The following is a description of a gene set: The glycosylation of protein via the O3 atom of peptidyl-serine, forming O3-glycosyl-L-serine; the most common forms are N-acetylgalactosaminyl, mannosyl, galactosyl, and xylosyl serine. Mouse Gene Set: GOBP_PROTEIN_O_LINKED_GLYCOSYLATION_VIA_SERINE studied in species Mus musculus, and this is the list of marker genes: Mgat5b, Poglut1, Poglut2 (NCBI Gene Id 79069), Galnt16, Galnt1, Galnt3, Galnt2, Galnt13, Poglut3, Galnt4